The following is a description of a gene set: Human Gene Set: GSE15930_STIM_VS_STIM_AND_IFNAB_24H_CD8_T_CELL_DN Genes down-regulated in comparison of unstimulated CD8 T cells at 24 h versus CD8 T cells at 24 h after stimulation with antigen-B7-1. studied in species Homo sapiens from publication Agarwal P, Raghavan A, Nandiwada SL, Curtsinger JM, Bohjanen PR, Mueller DL, Mescher MF (PMID 19592655) Differentiation of naive CD8 T cells into cytotoxic effector cells requires three distinct signals- antigen (signal 1), costimulation -B7-1 (signal 2) and cytokine, either interleukin-12 or interferon-a/b (signal 3). Interaction of naive CD8 T cells with antigen and B7-1 programs cell division and proliferation whereas the presence of cytokines- IL-12 or IFNa/b promote survival, differentiation and memory establishment. In the absence of signal 3, the cells interacting with antigen/B7-1 undergo tolerance induction. The objective of this study was to elucidate the mechanisms how the provision of signal 3 promotes differentiation and averts tolerance induction in CD8 T cells. Trichostatin A is a pharmacological agent that inhibits histone deacetylase activity, hence regulating chromatin structure and gene expression and differentiation in many cell types. Gene signature profiles of IL-12, IFNa/b and trichostatin A stimulated cells were compared to elucidate the molecular mechanisms of gene regulation. Oligonucleotide microarray analysis is carried out to determine the extent and molecular nature of the CD8 T cell differentiation program induced by IL-12 or IFNa/b in concert with antigen and B7-1 signal., and this is the list of marker genes: CBFA2T3, PRAF2, TENM1, TEKT2, LITAF, CA3, MORC4, FAM110A, STX2, CCDC6, TULP3, POLR3D, SYT7, P3H3 (prolyl 3-hydroxylase 3), LCT, PSMC1, E2F5, DEGS1, CAT, MEST, SENP6, COL8A1, C9orf78, PLAU, TIGD5, EIF2B4, CAPZA2, MSH3, CIDEC, TRHR, KTN1, KRT6A, TTF1, KCMF1, WNT10B, PCDH7, TUSC2, CCND1, NUP62, DUT, LAMA4, FOSB, PTPN23, GNPTG, TMEM30B, CRX, NKAIN1, CLPTM1L, EMC4, ZNF574, IL1R1, CCL4, NAA80, RASA4, EOMES, KCNK3, LDAF1, IL1A, OMD, KAT7, RGS4, SEC22B, SLC20A1, CMA1, INMT, FKBP5, MLLT1, PHLDA2, THAP7, SNX2, SWAP70, DEK, ENO1, GRPEL2, PRPF39, RAX, KLF4, ITGAV, CCDC28B, SEC23A, NAA11, HSPA5, MRPS18B (NCBI Gene Id 92039), SYNGR2, G0S2, MFNG, MXI1, CYP2A6, ZDHHC9, NCK2, SLC38A4, SLC6A6, SON, TBC1D23, TFEB, LAMA5, ZNHIT3, OR6A2, REG3G, KLF12, CD70, RNASE3, TPBG, CLP1, PEMT, SLC25A28, CAMK2D, MIF4GD, RENBP, HTR3A, MYO10, SAA4, PGAM2, RYK (receptor like tyrosine kinase), IFIT3, CCN1, VAPA, IER3, MRPS7, EPHB2, PRPF8, SLC35A2 (NCBI Gene Id 7355), CSRP1, PIP4K2C, MAPKAPK5, NRCAM, CCKAR (NCBI Gene Id 886), FCER2, POLR3A, RAB5A, CTSC, SLC30A1, MBD4, POU3F3, THBS3, GFRA1, CREBBP, MYT1, COASY, IFIT2, FRAT1, NCOA1, SIRT2, SAR1A, CFI, XCR1, CDV3, P2RX6, DVL2, KPNA6, HOXB7, GABRB1, SEPTIN4, FKBP10, DPF3, EFNA5, IBSP, COX7A1 (NCBI Gene Id 1346), MAST2, CELF1, SEPTIN10, MCM5 (NCBI Gene Id 4174, minichromosome maintenance complex component 5), HPD, TMEM230, CDKN2D, PSTPIP2, TMT1A, PON1, ROBO3, MRPL3, DCAF13, DDX10, RERE, DKK3, MTHFR, SEMA6C, TBPL1, DNAJB13, AFG2A, RIOX2, FOLR2, GJA4, KANSL2, IQGAP2, PRSS58, LGALS9B, FGD1, SLC22A12, SFTPC, TALDO1, UFD1, SRMS, THOC7, APBA2, OPRD1, TSFM, SRPK1, FZD9, NAB1